Given this list of marker genes H2ap, H2bc9, H2ab1, Macroh2a1, H2bc1, H2bc18, H2al3, H2ab3, H2ac15, H2az2, H2bl1, H2al1f, H1f4, H1f6, H2ac23, H2ac1, H2ac21, H2al2b, H3f3a-ps1, H3f5, H2aj, Lmntd2 (lamin tail domain containing 2), H3f3a-ps2, Cenpa, H2ac4, Macroh2a2, H2ac10, H2bc12, H2ac24, H2bc3, H2ab2, H2az1, H2al2a (H2A histone family member L2A), H2al1o, H2bc26, H2ac7, H2bc21, H1f5 (H1.5 linker histone, cluster member), Gm10257, Hmga1, H2ac6, H2ac19, H1f2, H2ac22, H2bc14, H2al1m, H2al1j, H2al1b, H2bw2, H1f1, H1f3, H1f0, H2bc22 (H2B clustered histone 22), Gm6421, H2al1e, H3f3c, Hp1bp3, H2ac25, H2bc27, H2ax, H2ac8, H2ac12, H2al1n, H2al1k, H2ac11, H2ac13, H1f8 (NCBI Gene Id 97324), H3f4, H2ac20, here is a description of the gene set: Mouse Gene Set: GOMF_STRUCTURAL_CONSTITUENT_OF_CHROMATIN The action of a molecule that contributes to the structural integrity of chromatin. species: Mus musculus